Given this list of marker genes EXTL3, REG3G, TP63, REG3A, HOXA7, OVOL2, SRSF6, EZH2, MSX2, here is a description of the gene set: Human Gene Set: GOBP_NEGATIVE_REGULATION_OF_KERATINOCYTE_DIFFERENTIATION species: Homo sapiens Any process that stops, prevents, or reduces the frequency, rate or extent of keratinocyte differentiation.